Given this list of marker genes CFDP1, ZNF652, QKI, TPM3 (NCBI Gene Id 91191), NIN, TNKS2, HMGN2, USP46, CA2, LRRC4, RBPMS2, NRXN1, TRIL, OTUB1, MCFD2, KPNA4, WTAP, PCDH19, XKRYP7, SUCO, NAA15, HOXA1, MPPED2, INTU, NEK6, HAPSTR1, BRWD1, GPBP1, NRGN, TRMT5, MAP3K3, RAD23B, SHANK2, CBFA2T2, EYA1, SNX22, ST18, GLYR1, TGFBR3, CSNK1G3, MAML1, BTBD7 (NCBI Gene Id 55727), PUM2, ELF5, CPSF4 (NCBI Gene Id 10898), ING3, EPS15, GREM1, MICU3, MAGI1, CEMIP2, ELF2, SOX11, KMT5A (NCBI Gene Id 387893), OTUB2, EGLN2, CALCR, CDK5R1, PRDM10, SH3PXD2A, MEIS2, NACC1, FOXO4, SMAD3, ADGRG2, NACC2, TNRC6A, TNK2 (tyrosine kinase non receptor 2, NCBI Gene Id 10188), CSNK2A2 (NCBI Gene Id 650690), BCL11B, AKAP12, SPSB4, EGR3, FBXO11, SNRPC, CHD7, RUNX1T1, ZFP2, TGIF1, CPEB2, NSD2, TTC7B, PDIA6, PPP1R13B, TBC1D15, SEC14L1, PAXBP1, STX12, TBC1D9, FOXK1, MAPRE1, PAPOLG, TRIB1, CXCL5, MEIS1, LHX4, DHX15, GJA1, DENND1B, RYBP, GLCE, EBF3, S100PBP, ARF6, TGFBR2, ASB15, LGR4, TOP1 (DNA topoisomerase I), TMED7, MAB21L2, THAP12, STAT5B, FUT4, SNX27, GRK5, TNRC6B, LPAR1, SYNJ1, SEPTIN3, RAI14, CIPC (CLOCK interacting pacemaker), ATXN1, LPP, FANCI, MAT2A, CHSY3, ADAM19, CADM1, RAB11FIP2, FNBP1L, EIF3A, FNIP1, IL6R, FAS, MARCKS, RCN1, RUNX2, PRTG, PLAU, KPNA1, MAGOHB, MTUS1, VAPA, AUH, CAMTA1, PICALM, ANKHD1, ATP6V1B2 (NCBI Gene Id 526), SEMA6D (semaphorin 6D), HOOK2, MSI1, CXCL12, TUSC2, NRXN3, STARD5, LHFPL2, ZBTB2, TLK1, HAS2, MRC1, WDR33, XKRY (NCBI Gene Id 9082), PKIA, DUSP5 (NCBI Gene Id 1847), SEC23A, ZNF395 (zinc finger protein 395), MAF, PPIF, ZIC1, ENTPD5, CUL3, HTR2C, NKAIN2, TOP2B, MAP3K21 (NCBI Gene Id 84451), ANO4, TMEM263, GPRC5B, HS6ST2, NUAK2, DLGAP2, TEAD1, PLPBP, FMR1, TMOD1, FBN1, ATP11B, ARHGAP27, DNM3, CDC40, PDE4B, AKIP1, NUAK1, FAM234B, PTK2B, HOXB4, RETREG3, GLS, GCC1 (NCBI Gene Id 79571), CLDN12, SLC6A14, SLC7A1, SIRPA (NCBI Gene Id 96784), DBNDD2 (NCBI Gene Id 55861), DMXL1, NAP1L5, PALS1, NCOA6, MYH4 (NCBI Gene Id 4622), GPC4, PKP4, KLF3, AUTS2, ANKRD50, MYH2, CPEB4, SETD2, ZNF579, SOCS6, HSP90B1, TRIM63, ZMYM2, CREBZF, KLF5, TAB3, ZEB1, C2orf69, INPP5A, TMCO2, CCNH, LIN28B, XIAP, NR6A1, RTF1, ASF1A, AMMECR1, WNK3, CCAR1, VSNL1, HMGXB4, ELOVL6, TMPO (NCBI Gene Id 7112), SCAF4, UBA6, UBE2O, TMEM131L, AZIN1, GREM2, SPRY2, CD163, KDM4A, TSHZ3, NAP1L1, SATB2, IPO5, PPP4R4, ARFIP1, LRIG1, CTCF, CELF2, MDFIC, NAA50, FAM13B, RBM25, G3BP2, TADA1, RFX6, FBN2, POM121, MAP3K5, PLCXD3, DMBX1, RNF43, CCDC6, MTSS1, GRK2, CLK3, MYH1, CLCN3, CHST7, HOXA3, AFF1, ADRA2B, PHACTR2, DIP2C, SPOCK1, LAMP1, PPP4R3B, PLAGL1, COLQ, HOXA11, SLC1A1, STK35, CBFA2T3, WDR20, PDE7A, TFPI2, PPP1CB, CTNNBIP1 (NCBI Gene Id 56998), IDH1, ETV1, PHF19, PRDM1, UBE2D3, PPP1R12A, ALDH1A2, CHUK, CFAP47, ZBTB18, YWHAG, PALLD, HYKK, FAM222B, HMGN2P46, BCL11A, IL11, UBE2D1, HNRNPU, RADX, NRK, DLX1, ZBTB44, MEX3C, MEF2C, MSL2, CIB2, HOXD10, B3GNT6, NDST1 (NCBI Gene Id 3340), CASP7, CCNG1, UBAP2, MAP4K4, FOSB, ZCCHC2, PHF21B, PLCB4, BTAF1, POU4F2, SMS, C12orf54, TOX, ABRAXAS2, GGNBP2, PPARGC1A, PITPNA, BLCAP, ADGRL2, HMGB2, CHST10, PAK6, SPOPL, WSB1, CRK, SLMAP, NUFIP2, HOXB5, DNAJC6, TGFA, B3GALT2, SRGAP3, IRF2, FOXL2, SATB1, SSH2, WBP2, SLC4A4, CCND1, SGK1, KDM6A, ERLIN2, HOXC11, VKORC1L1, CCL7 (NCBI Gene Id 6354), DOCK3, VGLL3, ATMIN, LRP5, CAB39, COL4A5, ZNF423, DLG2, MDFI, ARHGAP20, DACH1, NDFIP2, SNX5, ROBO2, CCNT2, MCM3AP, PKNOX1, OSBPL8, PPP2R5E, COL11A2, CAPN6, IRF1, RRAS2, BET1, ZNF655, LBR, NPR3, STX17, ATP6V1E1, KCNK3, MSMO1, AMBRA1, BORA, PTGER4, HNF4G, MET, KITLG, MARCKSL1, RSBN1, BNIP3L, CCK, ADAMTS6, NUP50, CSNK1G1, STK4, PRP4K, PKDCC, NCOA1, here is a description of the gene set: species: Homo sapiens Genes having at least one occurence of the motif AATGTGA in their 3' untranslated region. The motif represents putative target (that is, seed match) of human mature miRNAs hsa-miR-23a and hsa-miR-23b (v7.1 miRBase). Human Gene Set: AATGTGA_MIR23A_MIR23B